Given this list of marker genes COL6A3, ADSS1, TRIM32, RRM2B, TTN, GNE, POLG, VCP, HSPG2, MFN2, COL6A2, COL12A1, ANO5, PHKA1, GDAP1, TWNK, CRYAB, TNNT1, DMD, DYSF, POLG2, COL6A1, SLC25A4, here is a description of the gene set: Weakness of the quadriceps muscle (that is, of the muscle fasciculus of quadriceps femoris). studied in species Homo sapiens Quadriceps muscle weakness Human Gene Set: HP_QUADRICEPS_MUSCLE_WEAKNESS